Given this list of marker genes IL4R, GBP6, BATF, IL12B, GBP2, GBP4, IRF4, MIRLET7I, HRAS, TSPAN32, CD37, DEFA1, IL10, MYD88, IRF8, NKG7, DEFA1B, BATF2, DEFB130A, ARG1, LYST, CD40, GBP1, CLEC7A, PF4, VTCN1, GBP7, CCDC88B (NCBI Gene Id 84211), BPGM, SLC11A1, IER3, BCL3, SPN, here is a description of the gene set: Any process that results in a change in state or activity of a cell or an organism (in terms of movement, secretion, enzyme production, gene expression, etc.) as a result of a stimulus from a protozoan. studied in species Homo sapiens Human Gene Set: GOBP_RESPONSE_TO_PROTOZOAN